The following is a description of a gene set: Mouse Gene Set: GOMF_JUN_KINASE_BINDING Binding to JUN kinase, an enzyme that catalyzes the phosphorylation and activation of members of the JUN family. studied in species Mus musculus, and this is the list of marker genes: Hes1, Mapk8ip1, Spag9, Kif5b, Gstp1, Dusp16, Lmnb1, Tgif1, Rnf13, Mapk8ip2, Map3k1, Dusp10, Mapk8ip3 (mitogen-activated protein kinase 8 interacting protein 3), Atn1, Ptk2, Daxx, Mad2l2